Given this list of marker genes CA2, CA7, ATP8B1, ABCB1, GABRE, PRKG2, here is a description of the gene set: Any process that modulates the frequency, rate or extent of chloride transport. species: Homo sapiens Human Gene Set: GOBP_REGULATION_OF_CHLORIDE_TRANSPORT